The following is a description of a gene set: Human Gene Set: HP_DIGENIC_INHERITANCE A type of multifactorial inheritance governed by the simultaneous action of two gene loci. studied in species Homo sapiens Digenic inheritance, and this is the list of marker genes: ADH5, GDF6, GJB2, CLCNKB, LRIF1, GJB3, TYMS, SLCO1B1, GJB6, GDF3, CLCNKA, SMCHD1, SLCO1B3, NEK1, DNMT3B, DYNC2H1